Given this list of marker genes APPL1, PLSCR1, CSK, PTPRJ, LYN, RAP1A, RABGEF1 (NCBI Gene Id 27342), PTPRC, CD47, CD226, APPL2, here is a description of the gene set: Any process that modulates the rate, frequency or extent of the Fc receptor mediated stimulatory signaling pathway.. studied in species Homo sapiens Human Gene Set: GOBP_REGULATION_OF_FC_RECEPTOR_MEDIATED_STIMULATORY_SIGNALING_PATHWAY